The following is a description of a gene set: Human Gene Set: REACTOME_NICOTINATE_METABOLISM studied in species Homo sapiens Nicotinate metabolism, and this is the list of marker genes: NT5E, QPRT, PARP10, BST1, NMNAT2, PARP16 (poly(ADP-ribose) polymerase family member 16), CD38, SLC25A51, NMRK1, NAPRT, NADK2, PARP9 (NCBI Gene Id 83666), NAMPT, NAXE, NMNAT3, SLC22A13, NUDT12, NNMT, NADSYN1, PARP4, SLC5A8, PARP8, NMNAT1, PARP6, NAXD, NMRK2, NADK, RNLS, PARP14 (NCBI Gene Id 54625)